The following is a description of a gene set: Here we have used a systems biology approach to study innate and adaptive responses to vaccination against influenza in humans during three consecutive influenza seasons. We studied healthy adults vaccinated with trivalent inactivated influenza vaccine (TIV) or live attenuated influenza vaccine (LAIV). TIV induced higher antibody titers and more plasmablasts than LAIV did. In subjects vaccinated with TIV, early molecular signatures correlated with and could be used to accurately predict later antibody titers in two independent trials. Notably, expression of the kinase CaMKIV at day 3 was inversely correlated with later antibody titers. Vaccination of CaMKIV-deficient mice with TIV induced enhanced antigen-specific antibody titers, which demonstrated an unappreciated role for CaMKIV in the regulation of antibody responses. Thus, systems approaches can be used to predict immunogenicity and provide new mechanistic insights about vaccines. from publication Nakaya HI, Wrammert J, Lee EK, Racioppi L, Marie-Kunze S, Haining WN, Means AR, Kasturi SP, Khan N, Li GM, McCausland M, Kanchan V, Kokko KE, Li S, Elbein R, Mehta AK, Aderem A, Subbarao K, Ahmed R, Pulendran B (PMID 21743478) Genes up-regulated in plasmacytoid dendritic cell 7d vs 0d in young adults (18-50) after exposure to FluMist, time point 7D species: Homo sapiens Human Gene Set: NAKAYA_PLASMACYTOID_DENDRITIC_CELL_FLUMIST_AGE_18_50YO_7DY_UP, and this is the list of marker genes: LSM1, WDR47 (NCBI Gene Id 22911), UBA2, DAB2, BLMH, UBTF, GDE1, SLC43A3, GNPAT, SRPK2, ASNS, ARF4, PBX3 (NCBI Gene Id 5090), GOSR2, VSNL1, ACTA2, GLUL, CCDC90B, WDR1, TEX10, SCP2 (NCBI Gene Id 6342), MOAP1, MBD4, UBE2J1, KCTD12, RBMS1, SDHAF3, MPRIP, KDELR2, PALM2AKAP2, REXO2, WDR70, RAPGEF2 (Rap guanine nucleotide exchange factor 2), AFG3L2, GCSH, ZNF7, UBE2L3, CEP68, LUC7L3, SPAG9, RCAN1, PPP2R3C, RABGGTB, EWSR1, DAPK1, HIBCH, F8A3, IBTK, ERAP2, POT1, MED28 (mediator complex subunit 28), NAE1, TANK, AVL9, MARCHF7 (membrane associated ring-CH-type finger 7), FAHD2A, PNISR (PNN interacting serine and arginine rich protein), SENP6, TRIM27, ADI1 (NCBI Gene Id 55256), ATP2C1, NUP98, RIT1 (Ras like without CAAX 1), SLC11A2, BRIX1, WASHC4, COG8, KRT10, P2RY14, GRK3, CFAP298, DNAJC10, DESI1, PRNP, DLEU1, CIZ1, MAP1LC3B, NUDT15 (NCBI Gene Id 55270), CSNK1D, PDE4DIP, ZFTA, ARL1, RAD51AP1, RNF14, TUBB3, EIF3B, ROCK1, GSTM4, MLEC, API5, DGCR2, ABCC4, ZNF117, UBE4B, GLRX, MED31, CPD, HSPA4, LONP2, HAUS3, CCR1, MFN1, PPP1R11 (protein phosphatase 1 regulatory inhibitor subunit 11), RBCK1, PAIP2B, ANKHD1-EIF4EBP3, GPD1L, SP4, IQGAP1, ZBTB33, NFX1, PSMD14, RDH14, MAPK1, SEC24A, FAM3C, SLC33A1, LARP4B, SUN1, DICER1, GOLPH3, F8A1, KMT2A, TSNAX, GNAL, DGUOK, PAFAH1B1, SNAPC3, BANK1, MAP7D3 (MAP7 domain containing 3), NOL9, UCP2 (NCBI Gene Id 7351), USP15, CARD8 (caspase recruitment domain family member 8), NR3C1, RAB5A, OSBPL9, BUB3, NCBP2, PWP1, CYFIP1, THBD, RAB7A, TSPAN31 (tetraspanin 31), PSMB6, MCM3AP-AS1, ATP2A2, DBF4, RGS1, NFU1, CARS1, SETX, RABGAP1L, IDI2-AS1, MALT1, TRPV1, MCM4, AKT3, COIL, GCOM1, ATG12, UBL3 (NCBI Gene Id 5412), RFWD3, ENPP4, LRPPRC, HUS1, VCL, RAB3GAP2, MEF2C, THUMPD1, CSRP2, MTDH, ITPR2, CFAP20, NCOA6, PJA2, SERINC3, ZC3H14, ALDH5A1, CAT (catalase), IPO5, LAMP2, ABCB4, PTEN, RAB38, METAP1, SH3BP4, COX15, SIDT2, KLHDC2, KRCC1, DAD1, CCDC91, SCYL3, SNAPC5, TAX1BP3, QKI, HS3ST3B1, AFF1, SKIC3, ADNP, ZNF354A, MCC, SLC5A3, SEL1L, CARF, MAPKAPK3, SETD6, MARS1, MBNL1, PRDM2, ZMYM4, EIF2B1, ATP5F1C, UBR7, NME8, VPS26C, CLTA, RPS6KA3 (ribosomal protein S6 kinase A3), BTK (Bruton tyrosine kinase), MAT2A, EDRF1, DYNC1H1, SLC7A6, OPN3, SOS2 (SOS Ras/Rho guanine nucleotide exchange factor 2), DR1, NFYC, MON2, DCAF7, ARHGEF7, PAFAH2, WAPL, PPP3CB, COBLL1, SMAP1, LRRC40, CENPJ, PRDX4, MEAF6, CDK2AP1, DERL2, RO60, MRPL48, TRAPPC10, BTBD3, RGS2, DARS1 (aspartyl-tRNA synthetase 1), TMUB2, DMXL1 (Dmx like 1), PLAAT3, ADAM10, HIP1, ERO1B, SNX13, CENPU, FECH, INTS1, ST6GALNAC4, ZBTB18, CCZ1, MTX2, DDX27, ENTPD6, CSF2RA, ARL3, UBE4A, AGA, PIK3CA, TLR7, ERCC1, PDF, LYRM4, CYBC1, GLS, CAPN7, UBAP1, AACS, ZNF544, TRAM2, TRAK1, DNAJC8, NSDHL, IARS1, MLX, DMXL2, MAGEH1, MTERF3, FLOT1, NAGA, PRKAG2, BEX4, GPR183, HSPA13, FIBP, RPF1, OBSL1, CNDP2, CNOT1, TBC1D4, CEP350, PDHB, MRPL33, HGSNAT, SH3GLB1, CCT2, SMIM7, MAK16, LRBA, RET, EIF2S2, COG2, APC, RANBP1, H2AC6, TOB2, WDR37, CCND2, SC5D, TRAM1, ICE2, TRMT61B, KIF1A, RAB33B, SMARCAL1, TBPL1, GTF3A, PDIA5, SUZ12, TRIP11, DCP2, IKBKB, KIN, FUT4, ACAT1 (NCBI Gene Id 38), PEX13, LPGAT1, EIF3G, ANKFY1, PNOC, RITA1 (RBPJ interacting and tubulin associated 1), TPRKB, CMTM6, EGLN1, ADAM22, EIF5B, NAPA, SAE1, CRELD2 (NCBI Gene Id 79174), RUVBL2, LHFPL2, MIR22HG, DNAJC9, TMEM38B, CRIM1, SYNE2 (spectrin repeat containing nuclear envelope protein 2), OSBPL8, S100A10, NPIPB3, LAMP5, KPNA5, GNS, CLIC3, AMIGO2, DMAC2, TMPO, OTULINL, RMND5B, RUFY3, ECH1, ZNF83, HSF2, SACS, RIOX1 (ribosomal oxygenase 1), TUBGCP4, ASF1A, FANCI, BTG1, GNB1, XRCC5, PRELID3B, ITGAV, GEMIN2, CETN3, VPS11, ARK2N, RALGAPA1, ESD, PDCL3, DNAJB9, CCDC93, STX18, ZNF195, ZBTB10, AGO2, OXSR1, IFRD1, SCN9A, CMKLR1, RPA3, FKBP5, PPP1R12A, ERBIN, MTM1, CCZ1B, UBAP2L, ARG2, LRCH3, ST13 (NCBI Gene Id 8937), MDN1, R3HDM1, BTAF1, PAK2, KDM4A, GSPT1, GMFB, SRSF6, ELMO2, CMPK1, LIMS1, ATP13A3, CCND3, NPEPPS, APOOL, IDI1, DHFR, IFT74, CEP57, TDRD3, ARHGAP12, TPM4, MPP1, SLC35A2, USP9X, PEPD, CLIP1, LRRFIP2, PRPF6, MATR3, MSH3, SEC31A, TMCO1, ANXA4 (NCBI Gene Id 307), POP5, STK26, ASCC3, PTP4A1, SLC18A2, PPP3CA, WASF1, WASHC2A, EGR1, FHL1, APOBEC3G (apolipoprotein B mRNA editing enzyme catalytic subunit 3G), AK1, CDK12, ZNF202, CAP1, INTS15, DCK, CCNT2, TMEM184C, KYAT3, TDP1, SLC38A1, DZIP3, RGS10, MANF, RCN2, ATRAID, STN1, RASA1, CDK2AP2, TMEM185B, TMX4, PPP1R16B (protein phosphatase 1 regulatory subunit 16B), PTPN11, FLOT2, SP110, RBL2, HNRNPDL, XPO1, TMED5, SCUBE3, ECPAS, IPO7, MBD1, SAC3D1 (SAC3 domain containing 1), PHKB, FAM13A, NRP1, TCF4, MAP3K7 (mitogen-activated protein kinase kinase kinase 7), EIF3M, UBE2E3, TMED10, NUP210, ADK, PAXIP1, HSDL2, YWHAE, PCM1, JPT2, PLVAP, MAPK14, PTGER4, NOP56, PLEKHB2, PPP2CB, FDFT1, PSMA2, WIPF2, KMO, CCDC86, COPS6, ALG13, BIN1, LCP2, SPG7, CSE1L, MTRR, FLNB, NOD1, FMR1, WASHC3, KCTD20, RPL13, GYG1, EBP, TAF1B, WSB2, AZI2, ODC1, GNL3L, KLHDC10, SERP1, TRIM33, C10orf88, C12orf43, NUBP1, THAP1, ATRX, SPOP, PLIN3, NOTCH4, ZNF814, YWHAQ, SMURF2, SNCA, NADK (NAD kinase), ITGA4, FASTKD1, UBE2D3, ABHD2, DCAF13 (DDB1 and CUL4 associated factor 13), C11orf21, TCP1, PTBP2, SMIM8, PAPOLA, CREBZF, PPP2R5C, RSAD1, TAF12, CYFIP2, SLC25A32, PRKDC, SLC24A1 (solute carrier family 24 member 1), INTS7, NUDT3, ABCB1, ABRAXAS2, GPBP1L1, OAT, FCMR, GALNT1, KDM3B, WBP11, ENOPH1, H4C8, PYROXD1, CCT4, NFYB, RXRB, TBC1D1, AKAP17A, NOL8, PIP4K2A, OTUD4, ADCK2, TMBIM6, RPA2, FNDC3A, TTF1, MICU2, SEC22B, TWF1, DGKA, LMF1, GALNT3, CREB1, STAM2, UBR5, TRDMT1 (NCBI Gene Id 1787), UBE3A, DPP8, SLC4A3, AMD1, RNF13, NPM1, TSR1, AUTS2, ACSF2, BBS4, RCOR3, DUSP3, PUM1, CMAS, M6PR, RPAP3, GLOD4, GLMN, ZNF609, SMAD3, HMGCR, CD55, SLC16A7, YJU2, COPZ1, PRDM10, COPS8, LEPROT (NCBI Gene Id 83080), PSEN1, COPS2, MBNL2, APPL1, AMY1A, EDEM2, CAPZB, PCMT1, ANXA2 (NCBI Gene Id 792), ARHGAP24, BLOC1S5, SPCS2, ATP10A, MSRA, MRS2, SEC23B, PSMD4, SMARCC1, SHMT2, FASTKD2, TRIM38, CNOT4, MRFAP1L1, SSX4B, GK, HIPK3, ARL8B, PRKCI, RAD17, USP1, MSL2, MRPL3, PRPF8, TXNDC5, RSRP1, FIRRM, C1QBP, COPB1, DESI2, IL4R, RNF139, PDCD2, ZNF106, UQCR10, MGAT4A, ZBTB25, ECHS1, LAMC1, PRKACB, SMYD2, KTN1, ZNF148, AMY1B, MRPS17, DENND10, TBL2, RALBP1, COMT, ANKRD17, DNTTIP2, GTF2A2, ERG28, EXOSC8, GRPEL1, CCDC59, XRCC4, EEA1, RBM8A, CELF1 (CUGBP Elav-like family member 1), RMDN1, ITGB3BP, GATB, IRF2, OPA1, DSG2, BABAM2, RAB40B, CELF2, RNF130, RMDN3, NKAPD1, WSB1, PPIG, KARS1, SPAST, NCK2, TERF2IP, PYGB, R3HCC1 (R3H domain and coiled-coil containing 1), ATXN1 (NCBI Gene Id 7912), ASMTL, IL18RAP, AP2B1, FAF1, GLRX3 (NCBI Gene Id 414229), PLCL2, SLC35A3, ATM, LIN37, ZMYND11, CTNNA1, EBNA1BP2, UPF2, PLK4 (polo like kinase 4), ZC3H15 (zinc finger CCCH-type containing 15), BCL11A, CSNK1A1, SERINC4, THOC7, MED7, MYCBP (NCBI Gene Id 26292), CHTOP, ZNF124, BZW1, KPNA2, ARHGAP17, RRBP1, ANKMY2, RDH11, GADD45A, TCL1A, SPTBN1, PRDX6, FAM117A, SUMO1, RHOT1, INPP4A, TMEM59 (NCBI Gene Id 9528), PDE12, HADH, SOD2, KPNA1, APPBP2, ISCA1, CUL5, MGAT5, CNTRL, ARHGAP15, CUEDC1, CDC16, TMEM70, EPRS1, GLCE, OXCT1, PRKCA, CA8, CALCRL, SLC7A1, ERLIN2 (NCBI Gene Id 140906), TOP3A, GPR107, PGM1 (phosphoglucomutase 1), INTS6, MRPS16, ZFP36L2, NCF4, ADA, MTR, ZNF224, ELAVL1 (NCBI Gene Id 1994), EMC2, GOLGA4, RHOQ, RETREG2, TIMM17A, USP6, AK2, ATF2, PARP2, WDR3, ATP9B, RAB6B (RAB6B, member RAS oncogene family), MTMR1 (NCBI Gene Id 8776), MCUB, LPCAT3, LRRC8D, CISD1, DXO, PRPF38B, OSTF1, UBA3, DENND4B, ATF1, AMY2B, TFCP2, ENTPD1, SFSWAP, HARS1, PLXNC1, MRPS15, ENO1, TOR1B, C11orf24, MGMT, VPS45, FEM1B, TACC1, DDX19A, CUL4B, IL6R, INSIG1, CHST11, U2AF2, ZMYND8, NOC3L, PSMG1, TOPBP1, RIPOR2, ATP6V1A, SLC30A9, EPM2A, ENPP2, NR4A3, CUTC, NIPA2, EPS15, TPD52, MARCHF6, TOR1A, RPS6KA4, CITED2, HECTD3, UTP11, EXOC5, ALCAM, ACTR6, TTC13, TAF4, AMY1C, KCNAB1, POP4, ADAM9, ZNF337, TCF3, DAAM1, PDCD10, SLC25A46, DECR1, PTBP3, TASOR, SEC62, SUPT3H, ARIH1, SMARCA5, MACF1 (microtubule actin crosslinking factor 1), ANGEL2, LTN1, GNAI3, POLR2M, WBP4, RGS7, VPS41 (VPS41 subunit of HOPS complex), TRAPPC8, WBP1L, MAP4K5, MEF2A, ZMYM2, HSPA5, RAP2C, RSL1D1, STAMBP, UTP25, KDM6A, EAF2, MMRN1, RRP1B, TMEM39A, TDG, UBE2B (NCBI Gene Id 7320), PRPF4, THOC2, DUSP6, TUBB4B, CDYL, RPP38, MAN2A2, HS3ST1, AREG, NCBP3, SLF2, RRN3, PSMD2, ELF1, ANKHD1, EIF2S1, TSC22D1, PGAP2, RIOX2, ETNK1, CNIH1, MDFIC (NCBI Gene Id 29969), TUBB, SCD, SH3BGRL, ERMAP, POLM, SUGP1 (SURP and G-patch domain containing 1), C1orf50, DHDDS, ERAP1, COX11 (NCBI Gene Id 1354), EPHB1, DIAPH1, CEP290, TIA1, NT5C2, ZNF226 (NCBI Gene Id 82199), MIA3, EML4, CDR2, OAS1, SLC4A7 (solute carrier family 4 member 7), GRHPR, PITPNA, SYK, CCT6A, WAC, PARVB, MAD2L1, DAP3, NEK9, VAMP1, ST3GAL1, SHQ1, ASNSD1, MSMO1, TRPS1, CAPN15, HSPH1, CDK13, ZNF277, CTBS, EFHC1, FEZ2, PKP4, AGTPBP1, CCNG2, OXR1, LILRB2, SRPRB, PHTF1, F8A2, RWDD2B, BCL2L11 (NCBI Gene Id 150819), PPP1CC, PPP1R10, FYN, HMGCS1, EIF1AX, SLC39A6, SPIN2A, RNF11, C2CD5, SNAP23 (NCBI Gene Id 8773), CHST15, CAPNS1, TTC3 (NCBI Gene Id 7267), ELL3 (NCBI Gene Id 80237), RBM15B, URI1, SUPT20H, SPOUT1, FGFR2, TBCCD1, ADD3, SH3BGR, CCDC47, PQBP1, ZNF131, SEL1L3, SLC35D1, N4BP2L2, SLC9A6, RBM28, YKT6, CREM, PI4KA, NR4A2 (nuclear receptor subfamily 4 group A member 2), RYR3, RNF8, JAK2, ATXN10, PSMA1, SIDT1, CD164, BUD31, NUMA1, WDR59, RBM41, UEVLD, UPF3A, CIAPIN1, RBBP6, ZCCHC24, AJAP1, TMEM50A, H2AZ2, U2SURP, PDIA6, USP4, S100PBP, TSC1, ASXL2 (ASXL transcriptional regulator 2), RFK, ANKRD49, BCL2L1, BAG6, UBFD1, STX6, IGHM, CEP63, PPP2R5E, MOXD1, E2F5, STIM1, IL27RA (NCBI Gene Id 9466), CAPZA1, EID1, ATAD2B, DDX6, NFAT5, ANXA7, DNASE1L3, KCNA5, UCHL3, P3H2, PPP3CC, UBR2, OCRL, TM2D1, MRPS18B, GPATCH2L, BMP2K, SENP3, DMTF1, TMCO6, AIMP2, RPS6KA2, PSMB8, CDK5RAP1, NIPBL, PAIP1, TLR6, ADD1, ANKRD10, ZNF207, RUBCN, MICB, CTSB, PRKCD, EFCAB2, C7orf25, SCYL2, TNPO1, CLCN3, NBN, P4HA1, AGPAT5, CLK1, CTBP2 (NCBI Gene Id 87435), CYRIA, YAF2, SMG1, DIMT1, TIMELESS, WASHC2C, MIOS, NECAP1, SSX4 (NCBI Gene Id 6759), SLC1A4, HSBP1, HMG20B, GSPT2 (NCBI Gene Id 83029), GTF2H5 (NCBI Gene Id 404672), AR, SIK1, NDST2, MPV17, HIC2, NUP160, DNAJC13, CCR2, TSC22D3, EVI5, LSM3, SNRNP200, CAND2, SLC15A2, BMPR2, RIMS3, PPP3R1, IL13RA1, ARF3 (NCBI Gene Id 377), CREBL2, EZH1, WIPI1, CNOT9, ATF7, ISG20, KRBOX4, PTP4A3, MTHFD2, IGFBP7, RCOR1, SEPTIN11, IQCE, COX16, ALG5, PBXIP1, CCNG1, UQCRB, CUL4A (NCBI Gene Id 8451), ZNF329, DDX42, STAT6, SESN1, POU4F1, SPIN2B, AMY2A, PFKFB2, ERP44, PUM2, APAF1, N4BP1, GPX7, HMG20A, TBCC, CBX1, REST, LDLRAD4, DPYSL2, SECISBP2L, ACACA, ENSA, CHD9, ARFGEF2, MZB1, ARAP2, BSPRY, ADRB2, HSPD1, TMED7, FLI1, BTG2, DPP3, GALNT7, MTF2, ZNF713, ZNHIT6, IQSEC1, GLO1, POLR3C, PPP2R5D, IFT52, FAR2, TMEM14A, CTNS (cystinosin, lysosomal cystine transporter), DERA, FLT3, PMP22 (NCBI Gene Id 5376), EFR3A, ACSL4, TBC1D5, RPE, PPP6C, PTPN22, TRIM14, RABL3, CAMSAP1, EIF3J, ST3GAL6, DNAJC24, MAP3K5, ACSL3, LSM5, BAZ1A, TMEM33, DCTN3 (dynactin subunit 3), LAPTM4B, TMEM131, GGH, RBM10, NSL1